Given this list of marker genes Clip2, Napsa, Rab7, Klk7 (kallikrein related-peptidase 7 (chymotryptic, stratum corneum)), Tmem63b, Ctsh, Klk5, Abca3 (ATP-binding cassette, sub-family A member 3), Krtdap, Sftpc, Rab14, Abca12, Lamp1, Sftpb, Spink5, Lamp3, Smpd1, here is a description of the gene set: species: Mus musculus A membrane-bounded organelle, specialized for the storage and secretion of various substances (surfactant phospholipids, glycoproteins and acid phosphates) which are arranged in the form of tightly packed, concentric, membrane sheets or lamellae. Has some similar properties to, but is distinct from, a lysosome. Mouse Gene Set: GOCC_LAMELLAR_BODY